Given this list of marker genes A2M, FLNA, SERPINF2, OLA1, STXBP2, FGB, CALM1, TUBA4A, ITIH4, ACTN1, ITGB3, VWF, SPARC, CAP1, VTI1B, PCYOX1L, SCCPDH, HGF, QSOX1, VEGFC (NCBI Gene Id 7424), IGF1, PHACTR2, GAS6, AHSG, SELENOP (NCBI Gene Id 6414), SERPINA1, PDGFA, TOR4A, TTN, BRPF3, CD109, TMX3, CDC37L1, LHFPL2, PDGFB, VEGFA, ALDOA, KNG1, VEGFB, MMRN1, VCL, PF4, HRG, FERMT3, TF, APLP2, WDR1, CFD, CD36, TAGLN2, ORM2, CALU, SPP2, SERPING1, CYRIB, TEX264, TGFB3, F5, APOA1, TGFB1, MANF, TMSB4X, ECM1, LAMP2, LEFTY2, SYTL4 (NCBI Gene Id 94121), ANXA5, LY6G6F, HSPA5, SOD1, FN1, TGFB2, PLEK, PFN1 (NCBI Gene Id 5216), RAB27B, FGA, MAGED2, HABP4, F13A1, GTPBP2, ITGA2B, SCG3, TLN1, RARRES2, PPBP, POTEKP, ORM1, CLEC3B, SERPINA3, TIMP3, ALB, A1BG, ENDOD1, APOOL, CD63, CLU (clusterin), IGF2 (NCBI Gene Id 492304), TIMP1, CHID1, CYB5R1, PECAM1, APOH, SERPINE1, SELP, CFL1, EGF, FGG, PROS1, ACTN4, ITIH3, PLG, ACTN2, APP, FAM3C, NHLRC2, CTSW, SRGN, VEGFD, PPIA, CD9, SERPINA4, ISLR, THBS1, LGALS3BP, F8, PSAP, PCDH7, ABCC4, here is a description of the gene set: part of: Response to elevated platelet cytosolic Ca2+ Platelets function as exocytotic cells, secreting a plethora of effector molecules at sites of vascular injury. Platelets contain a number of distinguishable storage granules including alpha granules, dense granules and lysosomes. On activation platelets release a variety of proteins, largely from storage granules but also as the result of apparent cell lysis. These act in an autocrine or paracrine fashion to modulate cell signaling. <br><br><br> Alpha granules contain mainly polypeptides such as fibrinogen, von Willebrand factor, growth factors and protease inhibitors that that supplement thrombin generation at the site of injury. Dense granules contain small molecules, particularly adenosine diphosphate (ADP), adenosine triphosphate (ATP), serotonin and calcium, all recruit platelets to the site of injury. The molecular mechanism which facilitates granule release involves soluble NSF attachment protein receptors (SNAREs), which assemble into complexes to form a universal membrane fusion apparatus. Although all cells use SNAREs for membrane fusion, different cells possess different SNARE isoforms. Platelets and chromaffin cells use many of the same chaperone proteins to regulate SNARE-mediated secretion (Fitch-Tewfik & Flaumenhaft 2013). Reactome Pathway: Platelet degranulation studied in species Homo sapiens